Given this list of marker genes Adam10, Cd81, Tspan9, Gp6, Pdpn, Samhd1, Tspan14, Tspan33, Scimp, Tspan15, here is a description of the gene set: Mouse Gene Set: GOCC_TETRASPANIN_ENRICHED_MICRODOMAIN species: Mus musculus A pre-organized unit composed either of adhesion molecules (mainly integrins and members of the Ig superfamily), signaling receptors and/or enzyme-enriched plasma membrane domains that compartmentalizes cellular processes. Tetraspanin-enriched microdomains might be specially suited for the regulation of avidity of adhesion receptors and the compartmentalization of enzymatic activities.